Given this list of marker genes EIF4A2, DIS3L2 (DIS3 like 3'-5' exoribonuclease 2), PABPC1, TUT7, PABPN1, EIF4A3, EIF4G1, PAIP1 (NCBI Gene Id 10605), EIF4B, EIF4A1, TUT4, EIF4E, here is a description of the gene set: part of: Maternal to zygotic transition (MZT) Reactome Pathway: Z-decay: degradation of maternal mRNAs by zygotically expressed factors species: Homo sapiens Maternal transcripts accumulate in the oocyte during oogenesis. Subsets of maternal transcripts are degraded during later development of the unfertilized oocyte and after fertilization of the oocyte. Zygotic decay (Z-decay) refers to the degradation of maternal transcripts by factors expressed by the zygotic genome after fertilization. In the zygote the YAP1:TEAD4 complex activates expression of TUT4 and TUT7 which then uridylate the 3' ends of specific, partially deadenylated maternal transcripts (inferred from mouse zygotes in Sha et al. 2020). The terminal uridylate residues recruit PABPN1 which recruits the 3'-5' ribonuclease DIS3L2 to degrade the mRNA (inferred from mouse homologs in Zhao et al. 2022). Absence of TUT4, TUT7, or PABPN1 results in altered mRNA abundances (inferred from mouse zygotes in Morgan et al. 2017, Sha et al. 2020, Zhao et al. 2022) and infertility. BTG4 expressed in oocytes and present in zygotes also plays a role in Z-decay possibly by recruiting the CCR4-NOT complex to deadenylate mRNAs prior to uridylation (inferred from mouse zygotes in Sha et al. 2020). Similar patterns of expression and mRNA decay are observed in human and mouse zygotes.